The following is a description of a gene set: studied in species Homo sapiens Reactome Pathway: Translesion Synthesis by POLH part of: Translesion synthesis by Y family DNA polymerases bypasses lesions on DNA template DNA polymerase eta (POLH) consists of 713 amino acids and can bypass thymidine-thymidine dimers, correctly adding two dAMPs opposite to the lesion. Mutations in the POLH gene result in the loss of this bypass activity and account for the XP variant phenotype (XPV) in human xeroderma pigmentosum disorder patients. POLH can carry out TLS past various UV and chemically induced lesions via two steps: (a) preferential incorporation of correct bases opposite to the lesion (b) conditional elongation only at the sites where such correct bases are inserted., and this is the list of marker genes: POLH, RFC1, SPRTN, PCNA, UBA52, UBB, RCHY1, RFC5, RFC4, RFC2, VCP, UBC, RPA3, NPLOC4, RPS27A, RPA1, RPA2, UFD1, RFC3